Given this list of marker genes KCNT1 (NCBI Gene Id 57582), HCRT, CLIP2, MEN1, TBC1D24, FLII (FLII actin remodeling protein), VPS37D, SRCAP, IQSEC2, INSR, TSC2, CAVIN1, GTF2IRD2, KMT2C, GRB10, CYP11B1, ALK, KISS1R (KISS1 receptor), GNAS, FKBP6, PWRN1, EHMT1, TRIM8, NEUROD2, CDON, TMEM270, TGIF1, KCNQ2 (potassium voltage-gated channel subfamily Q member 2), DYRK1A, MSL3, ZNF365, GLI3, FGF8, PTCH1, GNAO1, PIGT (phosphatidylinositol glycan anchor biosynthesis class T), MRAP, DISP1, CDKL5, BRAF, DHCR7, PNKP (NCBI Gene Id 11284), HNRNPR, SOX6, ALMS1, FREM1, STAR, SLC32A1, HSD11B1, CPLX1, PIGA, DMXL2, USP7, FLI1, PLAAT3, SPEN, PWAR1, KMT2D, CASK, PLCB1, SNORD116-1, KMT2B, CREBBP, ZIC2, ZNF526, TBL2, CYP17A1, CAV1, STK11, KANSL1, PRKAR1A, MC2R, FGFRL1, RAF1, EIF5A, LIMK1, NNT (NCBI Gene Id 23530), METTL27, H6PD, MAGEL2, PIGF, RFC2, SLC12A5, MKRN3, TONSL, PLAGL1, NPAP1, P2RY11, CTBP1, KDM6A, AIP, MLXIPL, OCA2, BUD23, LMNA, NR3C1, FOS, NODAL, DEAF1, TAF4, SLC25A22, DDX3X, EP300, LRP5, NRAS, DLL1, EIF4H, LHCGR, SOX5, LETM1, GTF2I, CNTNAP2, SCN2A, H4C5, KCNA1, GLI2, RTL1, DLK1, PIGQ, FOXH1, TNFSF4, BSCL2, GRM7, GRIA1, SCN1B, ARX, PCNT, STIL, TANGO2, NDN, MIA3, BAZ1B (bromodomain adjacent to zinc finger domain 1B), PPARG, GRIN1, SIK1, TSC1, MEG3, CRIPTO, HLA-DRB1 (major histocompatibility complex, class II, DR beta 1), NR0B1, RAB23, SNRPN, CTSH, TFE3, ELN, SIM1, SMAD4, IFNG, STX1A, TNRC6B, HSD3B2, EXT2, GAS1, HYMAI, PAPSS2, DNAJC30, MAB21L2, NF1, TP63, MMP2, RAI1, HLA-DQB1, ZEB2, SNORD115-1, KRAS, TXNRD2, PDE11A, SLC35A2, MMP14, HERC2, GTF2IRD1, NCF1, AGPAT2, PIGP, SIX3, SHH, HRAS, ITPR1, MOG, ASXL3, NFIX, SCN1A, NSD2 (NCBI Gene Id 7468), here is a description of the gene set: Early onset of sexual maturation Human Gene Set: HP_EARLY_ONSET_OF_SEXUAL_MATURATION An early onset of puberty, in this case early does not refer to precocious. species: Homo sapiens